Given this list of marker genes Rac1, Map3k9, Shc1, Myc (myelocytomatosis oncogene), Hmgn1, Map3k1, Daxx, Map2k4, Cdc42, Mef2d, Atf2, Grb2, Pla2g4a, Map3k7, Map2k6, Tgfbr1, Creb1, Stat1, Max (NCBI Gene Id 17187), Ripk1, Tgfb2, Hras, Traf2, Ddit3, Mknk1, Rasgrf1, Mapk14, Rps6ka5, Elk1, Tradd, Hspb1, Map3k5, Mapkapk2, here is a description of the gene set: p38 Mapk signaling pathway species: Mus musculus Mouse Gene Set: WP_P38_MAPK_SIGNALING_PATHWAY